Given this list of marker genes NXN, ADNP, EP300, TNXB, POLR1A, GTF2I, GTF2IRD2, AGR2, BCOR, B3GAT3, HIRA, VPS35L, BRF1, CLIC2, COMT, TMEM270, MMP21, IFT140, KRAS, COL1A2, SPRED1, MFAP5, MMP14, MTX2, ANK1, SMAD2, IFIH1, LTBP3, ACTC1, IPO8, CREBBP, TBL2, GP1BB, CLIP2 (NCBI Gene Id 84805), RPS6KA3, ZIC3, COL3A1, BAZ1B, NPR3, HRAS, TMEM94, PLD1, MYCN, WASHC5, LRPPRC, TMEM260, TRAF7 (NCBI Gene Id 84231), TTN, SMARCA4 (NCBI Gene Id 6597), FREM1, POLG, LIMK1, HEXB (NCBI Gene Id 3074), THBS2 (thrombospondin 2), BRAF, MYPN, TPM1, NDUFB11, DZIP1, JMJD1C, CITED2, TPM2, XYLT2, MYRF, LZTR1, FLNA, COL2A1, CCDC22, PCGF2, TPM3, RAF1, FGFR1, GATA6, RPL5, NOTCH1, ATP6V1E1, PKD2, DPYSL5, GNB2, ROBO1, JPH2, VPS37D, LMNA, NF1, CHST3, TLL1, COL5A2, PKD1, BMP4, BUD23, TBX1 (T-box transcription factor 1), CCNQ, METTL27, HGD, UFD1 (ubiquitin recognition factor in ER associated degradation 1), PRDM5 (PR/SET domain 5), DNAJB11, STX1A, GALE, HCN4, MCTP2, MAPK1, FMR1, FIBP, SELENON, KMT2D, NKX2-5, ALG5, ARVCF, GBA1, PLXND1, TGFBR1, SF3B4, EXTL3, SLC29A3, TGFBR2, FMN2, BGN, EIF4H, TAB2, FKBP6, SH3PXD2B, DCHS1, SMAD4, TGFB2, MLXIPL, SACS, RYR1, RFC2 (NCBI Gene Id 5982), TWNK, ZMPSTE24, RREB1, FOXF1, COX7B, ENPP1, SPRED2, SLC6A6, VPS13B, PTPN11, MED12, SLC34A2, COL5A1, SKI, GJA1, ROR2, PLOD1, ZNF469, PRG4, ABCC6, ELN, MYH6, B3GALT6, PIK3CA, IDS, NONO, NCF1, AEBP1, KDM6A, TBX5, MMP2, FBN1, CBS, DNAJC30, AGGF1, BICC1, VWF, CHD7, GNPTAB (N-acetylglucosamine-1-phosphate transferase subunits alpha and beta), DSE, FBN2, SEC24C, GATA4, XYLT1, DAW1, CHST14, GANAB, SMAD3, MYH7, ALG9, HCCS, ADAMTS15, HNRNPH2, COL1A1, YY1, GTF2IRD1, MAP3K7, TBX20, here is a description of the gene set: Human Gene Set: HP_ABNORMAL_ATRIOVENTRICULAR_VALVE_MORPHOLOGY studied in species Homo sapiens An abnormality of an atrioventricular valve. Abnormal atrioventricular valve morphology